Given this list of marker genes Prdx5, Prdx3, Prdx4 (NCBI Gene Id 53381), Prdx2, Prdx1, Selenof, Prxl2b, here is a description of the gene set: Mouse Gene Set: GOMF_THIOREDOXIN_DEPENDENT_PEROXIREDOXIN_ACTIVITY studied in species Mus musculus Catalysis of the reaction:-dithiol + a hydroperoxide =-disulfide + an alcohol + H2O.